The following is a description of a gene set: Absence or underdevelopment of the lacrimal gland. species: Homo sapiens Human Gene Set: HP_APLASTIC_HYPOPLASTIC_LACRIMAL_GLANDS Aplastic/hypoplastic lacrimal glands, and this is the list of marker genes: SLC25A24, SOX10, GJB6, FGFR2, GJB2, FGF10 (NCBI Gene Id 2255), FGFR3, FOXL2